Given this list of marker genes Lrat, Ppard, Cat, Dnmt3a, Abcb1a, Lipa, Cyp26b1 (cytochrome P450, family 26, subfamily b, polypeptide 1), Serpina7, Map1b, Rara, Rbp1, Cyp1a1, Tyms, Aldh1a2, Pitx2, Epo, here is a description of the gene set: Any process that results in a change in state or activity of a cell or an organism (in terms of movement, secretion, enzyme production, gene expression, etc.) as a result of a vitamin A stimulus. studied in species Mus musculus Mouse Gene Set: GOBP_RESPONSE_TO_VITAMIN_A